The following is a description of a gene set: Mouse Gene Set: GOBP_NEGATIVE_REGULATION_OF_SMOOTH_MUSCLE_CELL_MIGRATION Any process that stops, prevents, or reduces the frequency, rate or extent of smooth muscle cell migration. studied in species Mus musculus, and this is the list of marker genes: Tpm1, Igfbp3, Ilk (integrin linked kinase), Pparg, Drd4, Pdgfb, Egfl7, S1pr2, Nfe2l2, Apex1, Nf1, Gstp1, Abhd2, Ppargc1a, Slit2, Prkg1, Mef2c, Ndrg4, Lrp1, Ptpn1, Trib1, Adipoq, Rhoa, Gna13, Serpine1, Tafa5 (NCBI Gene Id 106014), Coro1b, Myh9, Aif1, Ppard, Park7, Myocd, Gna12, Bmpr1a, Cav1, Igfbp5, Sema6d, Gstp2